The following is a description of a gene set: from publication Rashi-Elkeles S, Elkon R, Weizman N, Linhart C, Amariglio N, Sternberg G, Rechavi G, Barzilai A, Shamir R, Shiloh Y (PMID 16314843) Cluster 4: genes repressed by ionizing radiation regardless of ATM status. Human Gene Set: RASHI_RESPONSE_TO_IONIZING_RADIATION_4 studied in species Mus musculus The ATM protein kinase, functionally missing in patients with the human genetic disorder ataxia-telangiectasia, is a master regulator of the cellular network induced by DNA double-strand breaks. The ATM gene is also frequently mutated in sporadic cancers of lymphoid origin. Here, we applied a functional genomics approach that combined gene expression profiling and computational promoter analysis to obtain global dissection of the transcriptional response to ionizing radiation in murine lymphoid tissue. Cluster analysis revealed a prominent pattern characterizing dozens of genes whose response to irradiation was Atm-dependent. Computational analysis identified significant enrichment of the binding site signatures of NF-kappaB and p53 among promoters of these genes, pointing to the major role of these two transcription factors in mediating the Atm-dependent transcriptional response in the irradiated lymphoid tissue. Examination of the response showed that pro- and antiapoptotic signals were simultaneously induced, with the proapoptotic pathway mediated by p53 targets, and the prosurvival pathway by NF-kappaB targets. These findings further elucidate the molecular network induced by IR, point to novel putative NF-kappaB targets, and suggest a mechanistic model for cellular balancing between pro- and antiapoptotic signals induced by IR in lymphoid tissues, which has implications for cancer management. The emerging model suggests that restoring the p53-mediated apoptotic arm while blocking the NF-kappaB-mediated prosurvival arm could effectively increase the radiosensitivity of lymphoid tumors., and this is the list of marker genes: BCL2L11, DCTPP1, H2AX, BASP1 (NCBI Gene Id 10409), RGS19, IL27RA (NCBI Gene Id 9466), DNAAF5, GMFG, DYNLT2, GPC4, MFSD1, PYGB, CA8 (carbonic anhydrase 8), IL7R, ATP4A, SP100, IFI16, RAD23B, BBS9, UBAP2L, MTPN, PYHIN1, CPS1, HMGCS1 (NCBI Gene Id 3157), KNOP1, GIMAP1, LIFR, HMGB2, E2F8 (NCBI Gene Id 79733), LGALSL, RAB7A, IFIT3, HERC4, IRGM, ZAP70, SOX2, PRKAR2A, YWHAG, SRP19, ATP2A2, SEMA4D, HLA-DOB, FAM114A2, JPH3, FOXL1, SF3A3, RMC1, PLK4